Given this list of marker genes DLL3, TMEM70, ING1, CHPT1, GATB, PCTP, TSHR, DUS2, TBC1D22A, ATP6V1E1, IGHA1, IRF4, VPS50, TLR7, TFEB, ITPR1, CEPT1, SIAH1, IQSEC1, LIN37, CYRIA, SIGLEC5, IRF8, NUP88, SEC14L1, ZNF410, TALDO1, PARM1, NUP133, FCER2, TMEM268, CACNA1A (NCBI Gene Id 773), HLA-DPB1, KCNE5, SLC7A7, ALOX5, H2AC6, INPP5A, RBM12, U2AF2, GNG7, IFNGR2, LLGL1, NDUFA8, E2F6, ZC4H2, UBE2J1 (ubiquitin conjugating enzyme E2 J1), ZBTB10, CLIP2, SOD1, UVRAG, MICALL1, MRPL13, USP22, XYLT1, TMEM62, CD83, EAF2, RUBCN, ADK, METAP1, CLN8, TST, FAT2 (FAT atypical cadherin 2), SPCS1, LAT2, MICAL1, STX7, NDUFAF1, SERTAD2, LY86, GATM, RNFT2, KCNQ1, SYPL1, MEF2C, TMEM156, CHD1L, TERF2, AGPAT5, APBA3, MRPL33, MZB1, HLA-DQB1, DLAT, COL9A3, EIF2D, KPTN, SPATS2, CLNS1A, GSTT1, NASP, PTPRN2, SEL1L3 (SEL1L family member 3), MRPL15, ISG20, MICAL3, SIDT2, MCM5, RAB14, PAX5, FBXO41, POLB, LRRK1, MAPK12, CLIC4, WWC3, HLA-DMB, ZHX2, MTMR1 (NCBI Gene Id 8776), LTA4H, CD200, IL4R, CDK14, CYBB, SMPD2, ATXN7L1, FAM30A, NT5E, SHMT2, PEX11B (peroxisomal biogenesis factor 11 beta), IRAK1, RAB31, HLA-DOB, ACP5, NKRF, BASP1, ST6GAL1, UQCRH, RASGRP3, FTH1P5, TOR3A, NUP93, EPB41L2, RUBCNL, IGHM, EPHX1, ZNF154, FA2H (NCBI Gene Id 79152), ENTPD1, SH3BP4, COQ2, SPATA6L, ZDHHC14, ZC3H4, CHFR, SLC2A5, RNF4, CLMN, MARCHF3, CAT, ECHS1, DBNDD1, CFD, SCPEP1, ARL4A, KCNN4, SYT17, SLC17A9, TBC1D9, CHRM4 (NCBI Gene Id 1132), ATP5MC1, OAS1, SCN2A, FCGR2C, PDLIM1, SIK1, MYO1E, HLA-DMA, SMARCAL1, UNC119, MRM2, CIRBP, ADO, CCNB1IP1, RUFY1, FAM193A, CCT2, PIGC, PECAM1, SLC15A3, MSL3, NDUFB6, FDPS, TXNDC15, MTFR1, REPS2, CUX2, PKIG, SEMA3B, TNS3, IRF7, ST13, BHLHE41, OPN3, FMO1, RPS27L, MCTS1, here is a description of the gene set: from publication Jeffrey KL, Brummer T, Rolph MS, Liu SM, Callejas NA, Grumont RJ, Gillieron C, Mackay F, Grey S, Camps M, Rommel C, Gerondakis SD, Mackay CR (PMID 16474395) In the present study we used Affymetrix oligonucleotide microarrays to produce gene transcription profiles for the major leukocyte types in humans. This comprehensive dataset enabled us to not only establish which genes were expressed in each leukocyte type, but also which genes were expressed in each subset after activation. The used of a comprehensive dataset of gene profiles from all the major human leukocyte subsets enabled a novel and powerful means for identification of genes associated with single leukocyte subsets, or different immune paradigms. Genes up-regulated in comparison of B cells versus effector memory CD4 T cells. species: Homo sapiens Human Gene Set: GSE3982_BCELL_VS_EFF_MEMORY_CD4_TCELL_UP